The following is a description of a gene set: Genes up-regulated in bone marrow-derived macrophages with heterozygous MLL4 knockout: control versus treated with LPS for 2h. Human Gene Set: GSE30971_CTRL_VS_LPS_STIM_MACROPHAGE_WBP7_HET_2H_UP from publication Austenaa L, Barozzi I, Chronowska A, Termanini A, Ostuni R, Prosperini E, Stewart AF, Testa G, Natoli G (PMID 22483804) Histone methyltransferases catalyze site-specific deposition of methyl groups, enabling recruitment of transcriptional regulators. In mammals, trimethylation of lysine 4 in histone H3, a modification localized at the transcription start sites of active genes, is catalyzed by six enzymes (SET1a and SET1b, MLL1–MLL4) whose specific functions are largely unknown. By using a genomic approach, we found that in macrophages, MLL4 (also known as Wbp7) was required for the expression of Pigp, an essential component of the GPI-GlcNAc transferase, the enzyme catalyzing the first step of glycosylphosphatidylinositol (GPI) anchor synthesis. Impaired Pigp expression in Wbp7-/- macrophages abolished GPI anchor-dependent loading of proteins on the cell membrane. Consistently, loss of GPI-anchored CD14, the coreceptor for lipopolysaccharide (LPS) and other bacterial molecules, markedly attenuated LPS-triggered intracellular signals and gene expression changes. These data link a histone-modifying enzyme to a biosynthetic pathway and indicate a specialized biological role for Wbp7 in macrophage function and antimicrobial response. studied in species Homo sapiens, and this is the list of marker genes: OSGIN2, SERPINB2, DLL1, OLIG2, MIR23AHG, MSANTD3, UPP1, AGPAT4, RNF144B, KCNJ2, AGK, CDC42EP3, DENND5A, SLC25A37, SAV1, MIR3142HG, EDEM2, CD226 (NCBI Gene Id 10666), SLC1A2, MAPK8, IL2RG, SGPP2, SOCS3, CISH, BCL2A1, ST3GAL1, FSD1L, S1PR3, PLAU, DNTTIP2, OLIG1, STEAP4, MAP7, IER3, ACSL5, GRAMD1A (NCBI Gene Id 57655), CCL4, ELOVL7, RPA4, RABGEF1, CYB5D1, MFSD2A, LAMB3, PDE4B, ZC3H12A, FNDC3B, UAP1, RGS16, STK26, RASSF8, TRIM36, MMADHC, F2RL2, AMPD3, NR3C1, GOLT1B, NFAT5, MYO10, TRIP10, NEDD9, TMEM39A, MAP3K20, SCARF1, IL1B, SAMD8, TBC1D9, HECW2, MAMLD1, PMEPA1, MCEMP1, TNFSF15 (NCBI Gene Id 9966), AKT3, VWA8, PTGS2, MIR3945HG, DYNLT3, PURB, MPZL1, PTPN12, CSTA (NCBI Gene Id 378889), PNPLA1, PROCR, MAP3K5, GK5, ACSL1, CT75, NFKB1 (NCBI Gene Id 4790), MIR9-1HG, CHM, CXCL8, BCAT1, HEY1, CHST15, CYLD, SMS, YRDC, LIMK2, C11orf96, MTF1, ETS2, TMEFF1, SMPDL3A, PRKD3, ACVR1B, CRACD (NCBI Gene Id 57482), TNIP3, OSM, SEPTIN10, PDE4DIP, NUP58, MAP3K4, UPB1, CTSLP8, EHD1, TNFAIP6, ABCA1, CCDC93, ITGB8, PLGRKT, NDP, DENND3, MIR155HG, IRAK3, IL1A, NSUN3, CDK5RAP2, LINC-PINT, IL1RAP, IL6, PLAUR, SLC2A3, PRR16, GRAMD2B, HS3ST3B1, NRIP1, SLC20A1, TAB3, FPR2, SOCS2, SENP1, NFKBIA, TMEM161B, LPP-AS2, SAMTOR, GSAP (gamma-secretase activating protein), NBN, CCND1, CCL23, SH3BP5, PGD, PTGES, IER5, TNF, TMCC3, CNKSR3, PHLDA2, G0S2, USP12, CCL20, F3, CTSL, MZT1, ST20, CLIC4, ZBTB10, CCL1, SH3PXD2B, WTAP, ADCK2, NRIP3, MTHFS, CXCL2, HBEGF, NPC1, LRRFIP2, GJB2, KBTBD2, MAP1LC3B, SOWAHC, PFKFB3, ATP6V1E2, RFTN1, KANK1, DIXDC1, AK4, MET, DCUN1D3, HRH1, CDS1, LINC01192, TNFRSF9, SOD2, TREM1, IL36G, PRKAG2-AS2